The following is a description of a gene set: Signaling pathways invoke interplays between forward signaling and feedback to drive robust cellular response. In this study, we address the dynamics of growth factor signaling through profiling of protein phosphorylation and gene expression, demonstrating the presence of a kinetically defined cluster of delayed early genes that function to attenuate the early events of growth factor signaling. Using epidermal growth factor receptor signaling as the major model system and concentrating on regulation of transcription and mRNA stability, we demonstrate that a number of genes within the delayed early gene cluster function as feedback regulators of immediate early genes. Consistent with their role in negative regulation of cell signaling, genes within this cluster are downregulated in diverse tumor types, in correlation with clinical outcome. More generally, our study proposes a mechanistic description of the cellular response to growth factors by defining architectural motifs that underlie the function of signaling networks. Genes whose expression peaked at 40 min after stimulation of HeLa cells with EGF. from publication Amit I, Citri A, Shay T, Lu Y, Katz M, Zhang F, Tarcic G, Siwak D, Lahad J, Jacob-Hirsch J, Amariglio N, Vaisman N, Segal E, Rechavi G, Alon U, Mills GB, Domany E, Yarden Y (PMID 17322878) studied in species Homo sapiens Human Gene Set: AMIT_EGF_RESPONSE_40_HELA, and this is the list of marker genes: SGK1, CDKN2AIP, CEBPB, CBX4, EGR3, CAMKMT, LDLR, CCNL1, IL6, HES1, IER3, CCNA1, ATF3, SEC23A, JUN, ID1, DUSP5, ZFP36, KCNJ12, ATL2, MBNL1, UBR5, RNF141, DUSP1, NFIB (NCBI Gene Id 4781), JUNB, PTGS2, PALMD, EGR1, MBNL2, SLC2A3, PIP5K1A, PIAS1, KLF2, KLF6, UBE4B, IER2, BCL3, DUSP2, BTG2, NR4A1, PPP1R15A